Given this list of marker genes NOTCH1, IFIH1, SMAD6, NKX2-5 (NCBI Gene Id 1482), GATA5, here is a description of the gene set: Human Gene Set: HP_THORACIC_AORTA_CALCIFICATION Thoracic aorta calcification studied in species Homo sapiens An accumulation of calcium and phosphate in arteries with mineral deposits in the intimal or medial layer of the vessel wall in the thoracic aorta.